The following is a description of a gene set: The migration of a T cell from the blood vessels into the surrounding tissue. species: Mus musculus Mouse Gene Set: GOBP_T_CELL_EXTRAVASATION, and this is the list of marker genes: Ccr2, Ripk3, Icam1, F11r, Fadd, Il27ra, Ccl5, Cd99l2, Crk, Med23, Itgal, Crkl, Ccl2